The following is a description of a gene set: studied in species Homo sapiens from publication Borjesson DL, Kobayashi SD, Whitney AR, Voyich JM, Argue CM, Deleo FR (PMID 15879137) Genes down-regulated in polymorphonuclear leukocytes 9h after infection by: S. aureus versus A. phagocytophilum. Polymorphonuclear leukocytes (PMNs) were obtained from healthy individuals in accordance with protocols approved by the Institutional Review Board for Human Subjects at the University of Minnesota and the National Institute of Allergy and Infectious Diseases. PMNs (107) were combined on ice with live S. aureus (108) or with live or heat-killed A. phagocytophilum (bacteria isolated from 5x106 infected HL60 cells for a ratio of 1 infected HL60 cell: 2 PMNs, ~ 5-20 A. phagocytophilum: PMN) in wells of a 12-well tissue culture plate (pre-coated with 20% autologous normal human serum). Unstimulated control assays received either buffer (for S. aureus comparisons) or clarified HL60 lysate (for A. phagocytophilum comparisons). Plates were centrifuged at 350 x g for 8 min at 4oC to synchronize phagocytosis and incubated at 37 deg. C in a CO2 incubator for the indicated times. At the indicated times, tissue culture medium was aspirated from the plate and PMNs were lysed directly with RLT buffer (Qiagen, Valencia, CA). Purification of PMN RNA and subsequent preparation of labeled cRNA target was performed as described in Methods. Labeling of samples, hybridization of cRNA with HU133A oligonucleotide arrays (Affymetrix, Santa Clara, CA), and scanning were performed according to standard Affymetrix protocols ( http://www.affymetrix.com/pdf/expression_manual.pdf ). Experiments were performed in triplicate, using PMNs from three healthy individuals for each treatment. Human Gene Set: GSE2405_S_AUREUS_VS_A_PHAGOCYTOPHILUM_NEUTROPHIL_DN, and this is the list of marker genes: KATNAL1, ZNF341 (zinc finger protein 341), ENSG00000267882, MYO9B, PGLYRP2, INVS, PTDSS2, PIGO, HERC3, KLC4, ZNF384, RGS12, ZNF496, USP30, GIMAP5, INTS1, NIPAL3, RALGPS1, B4GALNT1, GRK6, ART1, AP1G2, POLR3B, ERGIC1 (NCBI Gene Id 57222), GON4L, FBRS, SLC39A14, NUP188 (NCBI Gene Id 23511), TRIM39 (NCBI Gene Id 56658), ZMAT3, PRR3, ZNF512, RAB5B, PBXIP1, AGFG2, SNX33, PHACTR4, ANAPC7, UNG, GDPGP1, TESK2, E4F1, CIT, ZER1, ZNF180 (zinc finger protein 180), ZNF142, BAIAP3, C2CD2L, NMNAT1, DHX57, CAPN15, DLGAP4, SPTLC1, PXK, SIDT2, DNMBP, SZT2, PI4KB, MAMDC4, SRBD1, RBAK, TTLL3, C6orf118 (NCBI Gene Id 353266), STON1 (NCBI Gene Id 11037), KAT14, GGA3, KIAA0319L, VANGL2, DPY19L3, PML, CSAD, FGD3, ATMIN, IL17RB, PCSK7, ZFYVE26, RCCD1, COL7A1, POLRMT, RNF214, RNF31, CAMKMT, SUGP2, ZNF346, MICAL1, GABBR1, APBB3 (NCBI Gene Id 10307), SIKE1, PRAMEF8, TBL2, INPP5E, CLCN6, TSPOAP1, SLC20A2, TTC19, RANBP10, TOR1B, ATG2B (NCBI Gene Id 55102), MAPK7, METTL22, APBA3, FBXO31, CBX7, CILK1, CPTP, TEDC1, LENG1, KCNH2, CYB5R1, BCAS3, DDX46, ZNF563, H6PD, ABCC4, RINT1, KRBA1, TAF1C, ABCA7, MTHFR, TCHP, ARFGAP1, ANGPTL1 (NCBI Gene Id 9068), CRTC3, ARHGAP24, MPZL3, DEDD2, SEC22C, SLC35A4, TRIM56, RPAP1, PLXDC1, CCDC88C, ZNF692, PHF6, HELZ, WRN, CEP162, FBXL20, TAF1A, HIF1AN, DUS3L, CNNM3, LRRC45, HELZ2, RNF215, SBSN, ASB13, NRDE2, ERC1, USP2, ZZEF1, ATXN1L, ANKRD13D, PADI3, UBA7, RECQL5, FHIP2B, DHX35, VWCE, ASCC2, RCAN3, SUPT7L, C8orf58, H2AB2, XKRX, LCA5, CRCP, SCN2B, RNF157, USP45, VPS33B, PICK1, STK11IP, EME2, PARP11, SLC25A27 (NCBI Gene Id 9481), KLHL22, TARS2, MUS81, JMJD8, ZNF319, NLRX1, MBLAC2, FAM53B, CCDC93, CUL4A, AFMID, POLR3A, DCUN1D3, RBSN, WASHC1, PTBP1, RINL, IL12RB1, MCOLN1, TIAM1, TLE2, ALKBH1, FBXO30, ABCA3